The following is a description of a gene set: Any process that results in a change in state or activity of a cell (in terms of movement, secretion, enzyme production, gene expression, etc.) as a result of a testosterone stimulus. studied in species Mus musculus Mouse Gene Set: GOBP_CELLULAR_RESPONSE_TO_TESTOSTERONE_STIMULUS, and this is the list of marker genes: Slc39a9, Elk1, Rwdd1, Mup1, Sirt1, Rnf4, Akr1c18, Rock2, Mup11, Ar, Spp1, Msn